Given this list of marker genes APOC1, CIDEA, FUT1, LACTB, AGTR1, ENDOU, HNF4A, ADGRF5, CH25H, BRCA1, TBL1XR1, PANK2, RDH10, DGKQ, MIR548P, ORMDL3, SIRT1, PDK1, PLCG2, EGR1, LPCAT3, ASXL3, NR0B1, IRS1, HSD17B13, NR1H2, PSAPL1, LONP2, MACROH2A1, TAFAZZIN, NR1D1, ABHD6, BMP5, APOC3, TSPO, MBTPS1, PHB2, APOA4, MIR132, SNAI1, ERFE, CLCN2, CREB1, MIR27A, PDK2, MBTPS2, HTR2C, CTDNEP1, LHCGR, ZFP92, PROX1, FSHB, TM6SF2, KIT, GPLD1, SIRT2, APOC2, SERPINA12, GPRC6A, CIDEB, NR5A1, KAT5, TREX1, PLA2G6, PAQR3, ACSL3, FMO5, TRIB3 (NCBI Gene Id 57761), RAB38, SIRT3, FGFR4, RORC, GDF15, STAR, PRKAG2, PDK4, AVIL, MAPK1, LDLR, THRA (thyroid hormone receptor alpha), BCL11B, SLC45A3, FMO1, DCAF5, SLC27A1, NSMAF, QKI, REST, BMP6, ADRA2A, CCN1, INS, DISP3, C7orf50, HTR2B, PPARA, ACADVL, MTMR9 (NCBI Gene Id 83651), ABHD5, KLHL25, MFSD2A (NCBI Gene Id 84879), FMO4, MBOAT7, IL1B, NPC2, ENPP7, IGFBP7, MLYCD, CREBL2, POR, UGT1A4 (UDP glucuronosyltransferase family 1 member A4), BSCL2, AKT2, PNPLA2, SCARB2, MTLN, FGF1, UGT1A8, SPHK2, GOLM1, LMF1, PRMT3, RORA, SORBS1, BGLAP, HCAR2, SLC22A13, THRSP, MIR9-1, APOH, DGAT2, CES1, FBXW7, LEP, LDLRAP1, DHH, TMX1, PLAA, ABCA2, ANGPTL8, MIR1-1, SCP2, ZFP69, SERPINA3, FMO2, MLST8, CCDC3, GHSR, APOD, PLA2G3, RARRES2, ABCG4, ADGRF1, NFKB1, CAPN2, PDK3, MTMR1, APOBEC1, ABCB11, INSIG1, OPA3, APOA5, PIBF1, BMP2, SNCA, ABCA3, SEC14L2 (SEC14 like lipid binding 2), NR1H3, MTMR2, GPER1, MIR96, UGT1A1, EEF1A2, KAT2B (NCBI Gene Id 8850), PSAP, MLXIPL, ANGPTL3, UGT1A10, APOE, PLIN5, MIR16-1 (microRNA 16-1), AKT1, RNF213, KPNB1, AADAC, UBR4, NR5A2, IFNG, PGK1, C1QTNF2, ALK, TPK1, MIR182, PTGS2, GPS2, ZNF750, ABCD2, GGCX, ACER1, BBS4, NCOA2, MTMR3, LPCAT1 (NCBI Gene Id 79888), TNFRSF1A, ETFBKMT, ABCG1, DAGLB, CGA, FABP5, IRS2, PRKAA1, PAQR4, WDTC1, LPIN1, FABP3, NR1D2, UGT1A7, INSIG2, C3, ANGPTL4, EIF6, SIK1, H6PD, PDGFB, SREBF1, MIR29B1, GNAI1, DKKL1, PRKACA, DAB2, APOA2, WNT4, APPL2, RUBCNL, CHRM5, GPIHBP1, GFI1, AVP, NFE2L1, CLSTN3, DNAJC19, SCAP, ADIPOR1, MIR195, ADIPOQ, HPGD, APOA1, APOB, CERS2, UGT1A3, EPHX2, PDGFA, TYSND1, CIDEC, SREBF2, CRTC3, MIR30C1, ZMPSTE24, AVPR1A, AKR1C3, SAMD8, NR3C1 (nuclear receptor subfamily 3 group C member 1), TREM2, MIR342, UGT1A9, STAT5B, ARMC5, DDX20, MIR206, PPARGC1A, MTOR, PDE8B, ORMDL2, CEACAM1, SIRT4, PIK3CG, SCT, ACACB, FMC1, PDE3B, CYP7A1, TNF, ACADL, HTR2A, ADORA1, PRKCE, ORMDL1, XBP1, PLPP1, ABCD1, SPATA18 (spermatogenesis associated 18), UGT1A6, MIR185, CNEP1R1, GPR146, DKK3, ARV1, PRKG1, STAT5A, BCKDK, ELOVL5, MIR766, IDH1, GAL (NCBI Gene Id 51083), CPT1A, STUB1, ERLIN2, SCARB1, CHP1, CAV1, NCOR1, FGF19, SPHK1, EDF1, SORL1, PPARG, ATG14, SIRT6, PRKCD, ABCA7, PCK1, SNAI2, MIR204, AQP8, MIR127, MID1IP1, PPARD, TWIST1, DNAJC15, ID2, ATP1A1, LPGAT1, ZBTB20, AGT, ADM, MALRD1, HCAR1, SOX9, STARD4, NR1H4, CD74, MIR27B, GNB3, ERLIN1, OGT, MIR192, MIR33A, GIP, ASAH1, MIR98, TTC39B, RPTOR, here is a description of the gene set: studied in species Homo sapiens Any process that modulates the frequency, rate or extent of the chemical reactions and pathways involving lipids. Human Gene Set: GOBP_REGULATION_OF_LIPID_METABOLIC_PROCESS